The following is a description of a gene set: After entry and uncoating, the SARS-CoV-1 genomic RNA serves as a transcript to allow cap dependent translation of ORF1a to produce polyprotein pp1a. A slippery sequence and an RNA pseudoknot near the end of ORF1a enable 25 - 30% of the ribosomes to undergo -1 frameshifting, to continue translation of ORF1b to produce a longer polyprotein pp1ab. The autoproteolytic cleavage of pp1a and pp1ab generates 15-16 nonstructural proteins (nsps) with various functions. The RNA dependent RNA polymerase (RdRP) activity is encoded in nsp12, and papain like protease (PLPro) and main protease (Mpro) activities are encoded in nsp3 and nsp5, respectively. nsp3, 4, and 6 induce rearrangement of the cellular membrane to form double membrane vesicles (DMVs) where the coronavirus replication transcription complex (RTC) is assembled and anchored.<br><br>Programmed ribosomal frameshifting (PRF) may be regulated by viral or host factors in addition to viral RNA secondary structures. For example, PRF in the related arterivirus porcine reproductive and respiratory syndrome virus (PRRSV) is transactivated by the viral protein nsp1, which interacts with the PRF signal via a putative RNA binding motif. A host RNA-binding protein called annexin A2 (ANXA2) binds the pseudoknot structure in the IBV genome. Host factors in the early secretory pathway appear to be involved in DMV formation and RTC assembly: Golgi specific brefeldin A resistance guanine nucleotide exchange factor 1 (GBF1) and its effector ADP ribosylation factor 1 (ARF1) are both required for normal DMV formation and efficient RNA replication of mouse hepatitis virus (MHV), a prototypic betacoronavirus that infects mice (Fung & Liu 2019).<br><br> studied in species Homo sapiens part of: SARS-CoV-1 Infection Reactome Pathway: Translation of Replicase and Assembly of the Replication Transcription Complex_9679504, and this is the list of marker genes: CHMP3, CHMP4C, CHMP2B, CHMP6, 8b, UVRAG, PIK3R4, CHMP7, 9b, BECN1, 1a, CHMP4B, PIK3C3, CHMP2A, MAP1LC3B, SARS coronavirus, complete genome, rep, CHMP4A